Given this list of marker genes ABL1, ITGB4, GDF15, NOC2L, SSPOP, CHUK, BAX, S100A2, ADA, GPX2, PMAIP1, PRKCD, DST, EVPL, GADD45A, SMARCD3, CLCA2, PML, OGG1, FAS, SERPINB5, CDKN2A, TRAF4, EGR2, YWHAQ, SPATA18 (NCBI Gene Id 552857), TFAP2C, MDM2, JAG1, CDKN1A, IGFBP3, SP1, CABLES1, EP300, MFGE8, VDR, DICER1, SSRP1, NQO1, DHRS3, TP53I3, PLK1, IKBKB (inhibitor of nuclear factor kappa B kinase subunit beta), FLOT2, WWP1, PERP, HBP1, FDXR, TP63, AEN, SHH, ITGA3, BBC3, ITCH, here is a description of the gene set: Human Gene Set: PID_TAP63_PATHWAY studied in species Homo sapiens from publication Schaefer CF, Anthony K, Krupa S, Buchoff J, Day M, Hannay T, Buetow KH (PMID 18832364) Validated transcriptional targets of TAp63 isoforms